Given this list of marker genes Prmt1, Prmt8, Carm1, Prmt2, Prmt6, Fbll1, Ndufaf7, Fbl, Prmt9, Prmt5, here is a description of the gene set: Mouse Gene Set: GOMF_HISTONE_H2A_METHYLTRANSFERASE_ACTIVITY Catalysis of the reaction: S-adenosyl-L-methionine + a histone H2 = S-adenosyl-L-homocysteine + a methylated histone H2A. Histone methylation generally occurs on either an arginine or a lysine residue. studied in species Mus musculus